Given this list of marker genes UPF3B, GIT2, RAB5A, RAB28, MAEA, TNKS2, SMYD5, EMSY, MNT, SYT11, PUM1, RPN1 (NCBI Gene Id 6184), ATP5PD, CCDC174, NAPEPLD, PAGR1, HIF1A, RECK, MYNN, KDM6A, HIC2, C9orf163 (chromosome 9 putative open reading frame 163), STX10, TGM5, SCYL3, DDX6, TXNDC12, TCF4, ASH1L, HMGB3, DYNC2I2, TARDBP, OSBPL11, THAP1, CACNB2, CCNB1IP1, ZBTB40, SNX13, PATZ1, CYB5D2, SMCR8, BAMBI, MORN4, KIF15, YY1AP1, CNPY4, PIGV, TUG1, EIF5, ZFP37, PPP4R3B, PSMB5, RBFOX1, NCDN, TTI1, SEPTIN7, PCBP4, MGME1, B3GALT6, CASC3, ADGRL1, TOMM40L, YY1, MAP3K4, PNRC2, FIZ1, PPP1R12B, TRA2B, ODAD3, CCDC71L, ARF1, PPP1R15B, KMT2E, KIAA1143, SLC25A19, LRRC41, NFYC, PYM1, MTF2, RBM14, SLC26A6, YBX1, CCNK, ENSA, C21orf58, NDRG3, DZIP1, ADK, BCL11A, CRELD2, ATP5MC2, BOP1, TBC1D14, DGCR2, CHFR, NACA, ECH1, REXO1, MORF4L2, USF1, SNX5, TIA1, PMF1, ARMC8, ZNF524, ATP13A1, CNOT3, ZFY, DYNC1H1 (dynein cytoplasmic 1 heavy chain 1), HNRNPH3, HOXC6, GTPBP1, CPEB4, AP3D1, SPCS2, RIF1, UBA1 (NCBI Gene Id 8247), ZFX, ADO, DAP3, SLC39A7, TOP3A, EPC1, BTRC, ATF1, RALA, UBXN11, EIF4A1, BRCA2, ETV1, RAB22A, TPGS2, SFPQ, GBF1, PRRC2C, UBE3A, PIGL, RPL35A, ELAVL4, SNRPN, TIAL1, BTF3, SETD3, ARCN1, NCOR1, CCDC186, UQCRH, DDX23, RPRD1A, HMGXB4, CELSR3, ZC3H11A, RPRD1B, MAPT, WDR13, UBE2W, HOXC4, ZBTB4, DSCAM, RBM3, UTP4, ZZEF1, PIAS3, UBE2J2 (NCBI Gene Id 55482), FOXO3, SERBP1, UBE4B, ZNF41, TAX1BP3, ARNT, RXRB, ATP5PB, TSC1, PBX3, ALG12, TMEM187, FZD8, IRAK1, ZIM2, ATF4, PCIF1, TRIM8, PFN2, MTFP1, FBXL19-AS1, RPS8, TET2, PRPF38B, CHTOP, POLR2A, VAX1, MPDU1, RPP25L, PCNT, RCC1L, EEF1A1, DUSP26, APBB1 (NCBI Gene Id 322), ATP5F1A, POGLUT1, PTMA, PRKCSH, DENND4A, RNF26, MARK3, DEPTOR, RABL6, GIGYF2, SNAP25, TMEM69, TRA2A, HSF1, ZC3HC1, MIOS, TJAP1, RAD21, SNURF, CCDC6, STRN4, EP300, N4BP2L2, ZNF335, ENOX1, SZRD1, PEG3, CAMKMT, TAF6 (NCBI Gene Id 6878), SF3A1 (splicing factor 3a subunit 1), ABHD1, DOLK, RBM15B, WDR77, POU2F1, RIMS1, LYPLA2, FKRP (fukutin related protein), IER2, PTBP1, WIPI2, UBIAD1, CCND1, CLK2, ZBTB22, NASP, PREPL, ANGPTL5, ZDHHC5, EMC6, EXOC6, CSNK1A1, FUZ, here is a description of the gene set: Genes having at least one occurrence of the motif GCCATNTTN in the regions spanning 4 kb centered on their transcription starting sites. This matches the YY1 transcription factor binding site V$YY1_Q6 (v7.4 TRANSFAC). Human Gene Set: YY1_Q6 species: Homo sapiens